Given this list of marker genes Kras, Prkcb, Hras, Sphk1, Prkcz, Pdpk1, Kdr, Plcg1, Prkcd, Src, Rasa1, Vegfa, here is a description of the gene set: studied in species Mus musculus Mouse Gene Set: REACTOME_VEGFR2_MEDIATED_CELL_PROLIFERATION VEGFR2 mediated cell proliferation